Given this list of marker genes REST, KCNIP3, NPAS4, NR3C1, SRF, here is a description of the gene set: studied in species Homo sapiens Regulation of NPAS4 gene transcription Human Gene Set: REACTOME_REGULATION_OF_NPAS4_GENE_TRANSCRIPTION